Given this list of marker genes Dnph1, Pnp, Nudt9, Gda, Nt5c1b, Nudt16, Nudt1, Pnp2, Nt5c, Itpa, Nt5c2, Xdh, Nudt15, Nt5e, Adprm, Nt5c1a, Nudt18, Nudt5, here is a description of the gene set: Purine catabolism Mouse Gene Set: REACTOME_PURINE_CATABOLISM species: Mus musculus